The following is a description of a gene set: An abnormality of the lip. Abnormal lip morphology Human Gene Set: HP_ABNORMAL_LIP_MORPHOLOGY species: Homo sapiens, and this is the list of marker genes: ICOSLG, LTBP1, KCNJ5, PUS7, SLC6A17, TAF8, MESD, JARID2 (NCBI Gene Id 3720), PPP3CA, NUAK2, EPB41L1, CDH11, DHX9, GFRA1, RPS15A, PUF60, PKDCC, MYCN (MYCN proto-oncogene, bHLH transcription factor), NODAL, ZNF292, HGSNAT, PUS1, EVC, ADGRG6, LRRC32, CUBN, KRAS, XYLT2, SNAI2, MPDU1 (NCBI Gene Id 9526), NFIA, TRMT10A, POLR3A, PRMT7, ACTB, GATA5, ITGA8, AP3D1, ZDHHC9, TTC5, GJA8, IFT52, CCNQ, RPS10, KDF1, CERS3, TASP1, PREPL, MID1, SPP1, PAX6, AGR2, KRT6B, SUZ12, GREB1L, CTBP1, POMT2, FOXP1, ALOX12B, SLC39A4, JAZF1, FUCA1, UGP2, PWAR1, MYMK, KIF15, ENG, CSF1R, MAP3K7, PDHA1, GRIA1, CHST3, RPL9 (NCBI Gene Id 6133), WDPCP, SHMT2 (NCBI Gene Id 6472), STRADA, PHGDH, AP4S1 (adaptor related protein complex 4 subunit sigma 1), DPYSL5, CLCF1, NUP107, SMG9, AIMP2, MKRN3, FLT4, MYOD1, MFSD2A (MFSD2 lysolipid transporter A, lysophospholipid), HERC2, NDN, H3-3A, RNU4ATAC, TSPEAR, DOCK7, DMPK, CEP19, SATB1, THOC6, TENM3, POU4F1, SPECC1L, PRKCZ, VPS33A, NEXMIF, RPL5, ATIC, ODC1, AP1S2, STIL, KIDINS220, AMN, EXOC7 (NCBI Gene Id 23265), FREM2, HSPG2, MSX1, TMEM70 (transmembrane protein 70), ATP9A, KCNJ11, ANKRD17, DHPS, GRIA4, EIF4A2, DNMT3A, SLF2, PDCD6IP, MYO18B, RIT1, PERP, ANKLE2, FGD1, CAMK2G, KDM6B, GRIP1, PTDSS1, RNF135, KAT8, ORC1, GAS1, NAA20, MAPRE2, B4GALT1, TNRC6B, MECP2, MAPK8IP3, PYCR1, CAMTA1, HDAC4, RIPPLY2, SIX1, RAI1 (retinoic acid induced 1), PIGL, SLC2A1 (solute carrier family 2 member 1), UFC1, PIGU, HEATR3, PARS2, BBS2, NKX2-6, BCR, AFG2B, ERCC5, MAPK1, P4HTM, JMJD1C, STXBP1, PQBP1, SUMF1, BBS5, MMP23B, TALDO1, PIGQ, RAB3GAP2, EDA2R, IRF6, SYNE1, ZC4H2, GNA14, VPS51, CPLANE1, IL1RAPL1, DYRK1A, HMBS, CEP135, CDK6, GMPPA (GDP-mannose pyrophosphorylase A), PIGT (NCBI Gene Id 94004), FCGR2B, FHL1, CAMSAP1, KIF11, FOXC1, SCARF2, TBL2, CTNNB1, FLI1, UGDH, PPP1CB, SALL4, BBS10, ABL1, PLXND1, ERLIN2, DYM, SMAD4, DHX37, TRAPPC4, DYNC2H1, EXOSC2, IFT172, SMCHD1, CLCN3, ALDH6A1, RET, B3GALT6, UBE2L3, TTC8, SRD5A3, PLG, CEP290, SMARCC2, ESAM, EFTUD2, TNFSF4, TBCE, GABRD, LARP7, MAB21L2, IDUA, ROBO1, C12orf57, PRKACA, DDRGK1, SMC1A (NCBI Gene Id 8243), SKIC3, TREX1, CCDC32, TAOK1, SRCAP, KAT6B, KNG1, CC2D2A, TPR, SMOC1, ERF, BMP4, RPGRIP1L, SEC24C, CNOT1, MAB21L1, WAC, UBAP2L, C4B, COG3, FGFR1, KDM5C (lysine demethylase 5C), TUBB, B3GAT3, LBR (NCBI Gene Id 653311, lamin B receptor), HUWE1, CSGALNACT1, CHD2, GNAI1, OFD1, NSD2, ZNF699, STK11, SC5D, CTNND1, KATNB1, SMARCA2, HS2ST1, TUBGCP2, PPP2R5D (NCBI Gene Id 5528), BBS12, METTL23, PDE4D, ERCC2, SMC5, SLC6A1, IFT74, MCPH1, CDON, RAB3GAP1, FAR1 (fatty acyl-CoA reductase 1), GLA, FBN1, ALG9 (NCBI Gene Id 79796), IRF5, PAX9, EGFR, TBX2, PMM2, OCLN, EXOC2, POLR1C, COMT, CDC42, GLIS3, FBXO31, CKAP2L, ADAMTSL2, MSX2, UPF3B, VAC14, FKTN, YARS2, THSD1, GTF2IRD1, CWC27, AMMECR1, ALG11, ZMYM2, SCAF4, SLC25A24, IRX5, MED12 (mediator complex subunit 12), DDX3X, STIM1, SNX14, PIGO, WNT3, SEC23A, PTCH1, CASZ1, RAP1B, LMNB1, EXT2, GBA1, HIRA, PWRN1, CUX1, CNOT3, DIS3L2, TWIST1, KCNMA1, KRT6A, FCGR3B (Fc gamma receptor IIIb), MYL2, ASXL2, SLC45A1, CBL, QRICH1, SLC29A3, FLNA, ZBTB18, BPTF, PPP2R3C, ACSL4, TP63 (tumor protein p63), CREBBP, CHUK, CLTC, CHSY1, KDR, BBS9, DPM2, ABHD5, EMC1, RAF1, TSR2, GLI1, SEC31A, MYMX, FIG4, ZEB2, GRB10, EXOSC5, CCBE1, CACNA1A, HDAC8 (histone deacetylase 8), MAPKAPK5, NFIB, MKS1, ETS1, CDKL5, CRIPTO, CDT1, KDM3B, AP2M1, SUMO1, TMPRSS6, PRIM1, HNRNPH2, BAZ1B, NBN, MUSK, LARGE1, GPC6, SLC1A3, KDM6A, TCF4, AFF2, CERT1, OTUD6B, AMER1, KRT16 (keratin 16), DLG5, CHAMP1, CRKL, USB1, MOCS2, ESCO2, WNT5A, BRAF, NFIX, NCF1, AHDC1, PRKAR1B, DPYD, CEP295, CDK19, LMX1B, MYH3, PTRH2, ARVCF, GOLGA2, RIPK4 (receptor interacting serine/threonine kinase 4), CEP152 (NCBI Gene Id 23701), TNPO2, RPL8, SPIN4, BAP1 (NCBI Gene Id 8314), LEMD2, IFT43, NOG, MYT1L, FBXL4, MASP1, RFC2, DCPS (NCBI Gene Id 28960), GJB6, SARS1, CCDC22, GNPTAB, MGAT2, EXOSC1, PGAP2, SATB2, IFT57, EIF2S3, PSMC3, SEMA3E, NR4A2, ADAM17, SCNM1, PRKDC, ORC4, STAT4, PITX2, MPC1, TNIP1, CSNK2A1, RPS27, MDH1, BBIP1, FGFR2, TBC1D24, TMEM270, SMO, SMC3 (structural maintenance of chromosomes 3), PDPN, CHRNG, DPM1, LIFR, CCDC47, CANT1, SF3B4, BDNF, ASH1L, IL6ST, MED13, MOCS1, IFIH1, TRIP11, ALX3, KIAA0319L, MED12L, CITED2, ARHGEF2, FTO, RREB1, HIVEP2, MAP2K2, CDK5RAP2, FZD2, MTX2, ALX4, GDF11, INTS11, SOS2, MSL3, ERMARD, UBB, KARS1, ADAMTS3, DVL1, AP4M1, MEF2C, RPL15, AGO1, BLK, RSPRY1, NIPBL, UBE4B, NKAP, NCAPG2, ATN1, NSDHL, LRP4, CIT, TCF20, MTHFR, TRAF6, SMARCA4, RPS20, PEX26, MCOLN1, ANO1, HIC1, GLI3, CSNK2B, POLR1A, HPDL, INTU, VPS37D (NCBI Gene Id 171020), IL17RA, TTI2, TBX1, CYFIP2, IL10, SYT1, TSPAN7 (NCBI Gene Id 7102), TGM1, ZNF462, BMP1, TRAPPC10, BCL11A, ANGPT1, COG8, KCNJ2, KCNJ6, GTF2H5, AASS, GTF2I, COG7, PIK3CD, TGIF1, KRT17, ZBTB20, SOS1, H4C9, POLR3GL, ARID2, TLR7, FILIP1, RAC3, KCNN3, ZMIZ1, IFT122, TBX4, WARS2, CD96, STX1A, TRAF3IP2 (NCBI Gene Id 25997), EDA, EDNRA, RAP1GDS1, SCYL2, OGT, FBXO28 (F-box protein 28), KAT6A, DPF2, ACBD6, HECW2, AMPD2, GAD1, IL17RC, SSR4, POMT1, RPL35, RAB18 (RAB18, member RAS oncogene family), ALG13, HNRNPC, ARID1A, AFF4, PRDM16, KMT2A, ATP6V1A, CNTNAP2, TRIM8 (NCBI Gene Id 81603), IDH1, CR2, RBMX, MEOX1, AP4B1, ATRX, DDX6, SPTBN1, ADSL (adenylosuccinate lyase), NECTIN1, RASA2, GRIA3, GNE, PORCN, PACS1, AXIN2, AFF3, JUP, HOXD13, ATP6V1E1, DHX30, ZNF148, SETBP1, LMNA, KCNE5, CDH1, ALG12, STEEP1, CDK13 (cyclin dependent kinase 13), TPM3, EFNB1, RRAS (RAS related), SCN4A, BUB1, ATP6V1B2, RSPO2, EXT1, GTF2IRD2 (GTF2I repeat domain containing 2), MAP2K1 (NCBI Gene Id 5604), ACER3 (alkaline ceramidase 3), KCNJ8, PAH, TRAPPC14, YY1, IGF1R, EYA1, HYLS1, DBR1, TBX5, BCL11B, POR, GABBR1, TMEM94, MAGEL2, NSRP1, TRRAP (NCBI Gene Id 8295), BLM, SASS6, TNFAIP3, SLC9A7, KIF14, ALG1, PAX3 (NCBI Gene Id 5077), GATA4, WWOX, EVC2, SHH, MINPP1, CAST, ADAM22, GP1BB, SUPT16H, PIGA, CACNA1C (NCBI Gene Id 775), ROR2, KMT2C, TRAPPC9, GLUL (glutamate-ammonia ligase), MESP2, OPHN1, ATG7, LTBP4, TTI1, WASHC4, C4A, LTBP3, UBR7, EIF4H, TMEM147, SIM1, ATP1A2, SCUBE3, MAP1B, SON, TMCO1, RPS19, COG1, MADD, TCTN2, AGL, RPS7, IFT140, KAT5, LZTR1, POGZ, GPC4, KIF26A, MEG3, PDGFRB (platelet derived growth factor receptor beta), LIMK1, WT1, TBL1XR1, CTLA4, BRD4, ERCC1, KDM5B, PPP1R13L, NSMF, CACNA1I, PGM2L1, NAGA, CDK10, DRG1, RYR1, PLCH1, TAF4, CCDC8 (coiled-coil domain containing 8), DCHS1, TWIST2, COG6, ADAMTSL1, SETD1B, ITGAM, WDR37 (WD repeat domain 37), TMEM53, PTPN11, PIGN, HLA-DRB1, COLEC10, RPS24, WBP4, RIC1, RPL35A, BBS4, KDM1A, H4C3, MICU1, DISP1, DEAF1, FGF3, TLK2, PLAA, TRIM32, GATA6, COL2A1, WDR4, SOX11 (NCBI Gene Id 6664), PLPBP, SCLT1, CRTAP, NEB, SDR9C7, SHOC2, SDCCAG8, ASCC3, MCM7, ZIC2, NRAS, CYP4F22, CDC6, POLR1D, CYP26C1, NEK9, ZFX, GLI2, NCAPD3, INPPL1, NALCN (sodium leak channel, non-selective), MED27, GPC3, POC1A, EP300, SETD1A, PRDX1, AUTS2, GLB1, UBE2A, MCTP2, NKX2-5, PIEZO2, FOXH1, RPL26, WNT10A (NCBI Gene Id 93651), WDR62, RAB5IF, TAF13, CEP120, DDR2, ABCD1, PIGB, TRPS1, FOXL2, H4C11, USP9X, TXNL4A, SULT2B1 (sulfotransferase family 2B member 1, NCBI Gene Id 6820), OBSL1, GATAD2B, WDR19, INSR, THUMPD1, SNORD115-1, KDM4B, CHD8, TET3, DYNC2LI1, RECQL, MYL11, HK1, HMGA2, MALT1, EEF1A2, CRLF1, SKI, GATA1, ZPR1, MKKS, HSD17B4, CLCN6, ERCC6, FRAS1, GJA5, PSMD12, FGF20, ARSK, ARL6, ABCC9, BANF1, SMG8, NAA10, UFD1, NF1, SNORD116-1, IDS, KNSTRN, ALG8, CNTNAP1, SHANK3, ZSWIM6, NOVA2, ZNF407, MID2, IFT27, TNNI2, CHST14, AP1G1, PTH1R, SMARCE1, FLRT3, HRAS, MRAS, AP4E1, ARHGAP31, PPP1R21, NDP, HS6ST2, U2AF2, PURA, LUZP1, BRAT1, ATP1A3, KNL1, RRAS2, ZNHIT3, PRKACB (NCBI Gene Id 5567), DSC3, BRF1, PIGV, ORC6, GJB2, DSE, MGP, H4C5, CHD5, FREM1 (FRAS1 related extracellular matrix 1), GRHL3, NAA80, GDF2, CILK1 (ciliogenesis associated kinase 1), SLC35C1, ADNP, WNT10B, SOX9, PTEN, IER3IP1, ATP6V0A2, MAFB, PCDHGC4, IFT56, CLIC2, NELFA, UBE3B, RPS28, PIGW, NPAP1, BBS1, KMT2D, ARMC9, NEU1, ARX, SRRM2, FKRP, WNT9B, CEP63, GDF1, FMR1, SIN3A, RPL31, WDR35, SYNGAP1, BRCC3, HDAC6, MMACHC (NCBI Gene Id 25974), TBR1, FOXC2, RPS26, PGAP3, RIN2, FERMT1, RFX7, RPS23, RAD21, BCKDK, FOXF1, MYH8, MAN1B1, PROKR2, NARS2, SLC4A10, NOTCH3, GMNN, NLRP1, TFAP2B, ARNT2, DENND5A, FOXG1, NRCAM, RPL11, PPP2R1A, DLL3, LFNG, BRPF1, YAP1, IARS2, GNS, CDC42BPB, STAG2, PAK3, GPR101, SLC2A10, CTCF, ANKRD11, TGDS, TAPT1, XPNPEP2 (NCBI Gene Id 7512), UNC80, CASK, EXTL3, PACS2, NSUN2, SOX4, TCF3 (transcription factor 3), CRELD1 (NCBI Gene Id 78987), PPM1D, BUD23 (NCBI Gene Id 84118), LEMD3, GALNT2, PYCR2, BMP2, REV3L, TCTN3, PHF21A, RPS29, RPS6KA3, CUL4B, PTPRF, ZNF526, ALOXE3, ABCC8, TBCK, NPHP1, METTL27, UBR1, KCNK9, MBTPS2, NBAS, PDCD1, PPP1R15B, TGFA, SMS, FOXP2, KIAA0753 (KIAA0753), EBP, ASXL3, CENPE (NCBI Gene Id 1062), COL11A1, KCNH1, CFAP418, CLP1, SLC25A46, SIX3, OTUD7A, AARS1, EDARADD, KCNK4, ADARB1, OCA2, PXK, IFT80, NUP37, XRCC4, VAX1, IREB2, AIP, PIK3CA (phosphatidylinositol-4,5-bisphosphate 3-kinase catalytic subunit alpha), ITCH, NANS, B3GLCT, EFEMP1, RTTN, INTS1, LMBRD1, CHN1, JAG1, CCN2, RHOBTB2, POLR1B, CHD7, MTOR, HNRNPU, MEGF8, RPS17, PPP1R12A, EZH2, FRMD4A, RAB34, LIG4, CYB5R3, FGF8, RALA, GNB1, PIGS, EBF3, SETD5, CCNK, BANK1 (NCBI Gene Id 55024), IGHG1, CUL7, KATNIP, MYOF, FIBP, HOXB1, NONO, SLC35A1, WDR26, FBXO11, SOX18, TAF1, CYB5A, ATP7A, LZTFL1, ACVRL1, TRIP12, RUNX2, TOR1A, AGO2, BCOR, KLHL41, BUB1B, DVL3, DLX4, FGFRL1, RAB11B, AGA (aspartylglucosaminidase), OSTM1, TMEM237, LAS1L, ZMPSTE24, AP1S3, CACNA2D1, DLL1, PAM16, CDC45, DNASE1, RPL10, SNRPN, TFE3, PIDD1, SLC19A1, WLS, PAFAH1B1, PIGG (NCBI Gene Id 54872), TAF6, ASXL1, FKBP6, PRORP, OCRL (OCRL inositol polyphosphate-5-phosphatase), SCN1A, ADA2, TRPM3, HES7, DYNC2I1, ADAMTS2, CLEC7A, DDB1, EDAR, MED25, NSD1, BCAS3, EIF5A, RECQL4, SPEN, TBC1D20, NOTCH2, FRA10AC1, KDM5A, B9D1 (B9 domain containing 1), PHC1, SNIP1, SH3PXD2B, H3-3B, COX7B, SMARCB1, ZFPM2, SF3B2, BBS7, FLCN, FLNB, IQSEC2, SMARCD1, WARS1, FAT4, LRP6, KANSL1 (KAT8 regulatory NSL complex subunit 1), RBL2, RAPSN, CDH2, COL11A2, DHODH, C2CD3, STT3A, METTL5, CA2, ACTG1 (NCBI Gene Id 71), POMGNT1, MCM5, SLC46A1, COL3A1, SPRED2, MLXIPL, MED13L, RNU12, RPL18, IL36RN (NCBI Gene Id 26525), PIGK, NEK1, TRIO, FTSJ1, XYLT1, SCAPER, SREBF1, IFT81, MEIS2, DLK1, HNRNPK, BRCA1, ASPM, KCNAB2, ASPRV1, MARS2, LETM1, C1GALT1C1, NXN, EHMT1, ELN, YWHAE, HS3ST6, FLII, SLC26A2, SET, ACTA1, APC, CPLX1, COPB2, GJA1, ECM1, RTL1, VPS35L, PTPN22, IRAK1, HECTD4, PCLO, VPS13B, TGFB3, EDEM3, MRPS28, SPOP, TCOF1, IL17F, ADAT3, ANTXR1, LIPN, COLEC11, ITPR1, RNF2, PIGY (NCBI Gene Id 84992), RPL27, CNOT2, RERE, KIF7, VANGL2, MBD5, DYNC2I2, DDX59, RNU4-2, AP3B1, SNRPB, KREMEN1, GNB2, PHIP, PHF8, CHMP1A, EPG5, PCGF2, PPP2CA, SUFU, CASP2, PBX1, PSMB8, ARID1B, TOE1, MAF, CLIP2, WNT4, NIPAL4, PKP1, SMPD4, DHCR7, ABCA12, TFAP2A, KIFBP, CAPRIN1, AVP, DNAJC30, KIT, SLC35A2, TMLHE